The following is a description of a gene set: Genes predicted to be targets of miRBase v22 microRNA hsa-miR-659-5p in miRDB v6.0 with MirTarget v4 prediction scores > 80 (high confidence targets). Human Gene Set: MIR659_5P from publication Chen Y, Wang X (PMID 31504780) studied in species Homo sapiens, and this is the list of marker genes: AMACR, EHD1, DIS3L2, FASLG, NUDT3, KLC4, SLC31A1, KLRF1, AKAP12, STK38L, GOLPH3, RAB3C, RPS10-NUDT3, SHISA7, SOD2, SMARCE1, TGFB2, CEP41, ZNF549, FNBP1, PURA, OPA3, PCSK5, ATRN, LHFPL3, ECM2